The following is a description of a gene set: studied in species Homo sapiens Human Gene Set: REACTOME_MUSCARINIC_ACETYLCHOLINE_RECEPTORS Muscarinic acetylcholine receptors, and this is the list of marker genes: CHRM1, CHRM2, CHRM5 (cholinergic receptor muscarinic 5), CHRM3, CHRM4